Given this list of marker genes MIR410, MIR206, MIR150, MIR494, HSPB1, ADTRP, PACSIN2, NRP1, MIR200B, CD40, PTGS2, APOA1, MIR424, MAPK14, ROBO4, MIR487B, RHOA, MIR503, MIR146A, SP1, AMOT, SCARB1, HDAC9, ID1, MIR16-1, EFNB2, VEGFC (vascular endothelial growth factor C), MIR23A (microRNA 23a), CLN3, MIR27A, PRKCA, MIR27B, CDH5, MIR133B, P2RX4, FGFR1, AGTR2, MEOX2, MIR143, GPX1, TGFBR3, ITGB1BP1, SRF, CRIPTO, EFNA1, MIRLET7A1, NR2E1, MIR15B, DLL4, HDAC5, PRKD1, NOTCH1, ADAM17, HMOX1, TMSB4X, MIR329-1, FGF2, TBXA2R, EPHB4, MIR483, MIR499A, GADD45A, MIR200C, GAB1, PDGFB, ANGPT2, PRKD2, MIR31, MIR640, MIR129-1, SOX18, SIRT1, ETS1, PDCD10, AKT1, TNF, MIR221, CLEC14A, TGFB1, MMRN2, MAP2K3, EHD4, JCAD, JUP, MYH9, SH3BP1, NOS3, GPLD1, MIR24-1, ROBO1, MIR152, FGF18, MIR204, MIR10B, NR4A1, MIR29C, MIRLET7F1, CARD10, PRCP, EPHA2, KLF4, MAP2K5, HDAC7, PIK3R3, MEF2C, MIR92A1, GDF2, MIA3, ATP5F1B, MIR19B1, MIR137, MIR132, ANGPT4, MIR320A, MIR135B, MIR939, MIR497, EMP2, MIR30A, ATP5F1A, MIR210, MMRN1, ABL1, MIR193A, MIR2355, THBS1, ANXA1, MECP2, FGFBP1, CYP1B1, FOXC2, MIR149, SRPX2, HIF1A, KDR, MIR885, HMGB1, MIR22, SPRED1, MICALL1, PIK3C2A, VASH1, MIR495 (NCBI Gene Id 574453), VEGFA, MIR212, MIR200A, APOE, PLK2, ATP2B4 (ATPase plasma membrane Ca2+ transporting 4), MIR199A1, CTNND1, PLG, MIR296, PDPK1, PPARG, MIR10A, MIR505, MIR20A, HRG, MIR15A, MIR361, MIR126, GREM1 (gremlin 1, DAN family BMP antagonist), SLIT2, ITGB1, ACVRL1, STARD13, MIR196A1, AKT3, NF1, MIR205, RHOJ, NFE2L2 (NCBI Gene Id 4780), NUS1, CIB1, MIR492, MIR342, CSNK2B, MIRLET7B, RGCC, GATA2, MIR101-1, PLCG1, ANGPT1, EGR3, MIR26A1, STAT5A, here is a description of the gene set: The orderly movement of an endothelial cell into the extracellular matrix in order to form new blood vessels during angiogenesis. Human Gene Set: GOBP_BLOOD_VESSEL_ENDOTHELIAL_CELL_MIGRATION species: Homo sapiens